The following is a description of a gene set: Mouse Gene Set: GOBP_OUTER_DYNEIN_ARM_ASSEMBLY species: Mus musculus The aggregation, arrangement and bonding together of a set of components to form an axonemal dynein outer arm, an outer arm structure present on the outer doublet microtubules of ciliary and flagellar axonemes., and this is the list of marker genes: Lrrc61, Dnaaf6, Dnah8, Dnaaf1, Dnah5 (NCBI Gene Id 170953), Dnaaf5, Odad3, Clxn, Ccdc103, Dnaaf4, Dnai1, Odad1, Odad2, Dnaaf2, Ccdc63, Dnai2, Dnah17, Dnaaf6rt, Daw1, Odad4, Dnaaf11, Dnal1, Zmynd10 (NCBI Gene Id 114602)